The following is a description of a gene set: An assembly of four or five subunits which form a structure with an extracellular N-terminus and a large loop that together form the ligand binding domain. The C-terminus is intracellular. The ionotropic glutamate receptor complex itself acts as a ligand gated ion channel; on binding glutamate, charged ions pass through a channel in the center of the receptor complex. The AMPA receptors mediate fast synaptic transmission in the CNS and are composed of subunits GluR1-4, products from separate genes. These subunits have an extracellular N-terminus and an intracellular C-terminus. species: Mus musculus Mouse Gene Set: GOCC_AMPA_GLUTAMATE_RECEPTOR_COMPLEX, and this is the list of marker genes: Cacng2, Shisa9, Porcn, Gria4, Dlg3, Grid2, Vwc2l (von Willebrand factor C domain-containing protein 2-like), Shisa6, Cacng4, Gria3, Shisa8 (NCBI Gene Id 631752), Olfm3, Vwc2, Abhd6, Cpt1c, Dlg4, Cacng8, Nrn1, Abhd12, Sacm1l, Olfm1, Grid1, Shisa7, Cacng3, Cnih3, Cacng7, Gria1, Cacng5, Lrrtm4, Olfm2, Cnih2, Gria2